Given this list of marker genes Tcf15, Tcf21, Crebbp, Smad3, Ube2i, Tcf12, Bmal1, Twist1, Sp1, Csrp3, Foxh1, Ep300, Tcf4, Bhlhe40, Ascl1, Usf1 (upstream transcription factor 1), Myod1, Isl1, Ncapg2, Bhlhe41 (basic helix-loop-helix family, member e41), Scx, Sirt1, Figla, Fhl2, Hand1, Psmd9, Sox9 (NCBI Gene Id 70015), Kdm1a, Id3, Runx2, Usf2, Ascl2, Klf5, Map3k10, Tcf3, Lmo2, Ikzf4, here is a description of the gene set: species: Mus musculus Mouse Gene Set: GOMF_BHLH_TRANSCRIPTION_FACTOR_BINDING Binding to a basic Helix-Loop-Helix (bHLH) superfamily of transcription factors, important regulatory components in transcriptional networks of many developmental pathways.